Given this list of marker genes CCDC159, IPMK, TMEM184B, SOX15, ID3, FILIP1L, GSDMC, ZNF230, STX12, ZNF750, IRX4, PTGES, BTNL9, SAP130, ETV1, LZTS2, EDN1, HOXA5 (NCBI Gene Id 55953), TUBG1, TUT7, MEAK7, NFKBIL1, NR3C2, NR5A1, SPPL2B, ZNF252P-AS1, SLC4A9, DDX6, CLIC6, CYS1, SAMD11, GLDN, GALNT8, POLR1E, WNT10A, KRTAP2-4, NNMT, CACNA1I, KRCC1, TUSC2, TRABD2A, FLJ13224, NMNAT3, TRIM7, PYGL, ITPRIP, REXO1, NPL, FGGY, ACTR3B, DAD1, PBX4, FNBP1, CRMP1, BAZ2A, DNAL1, FXYD7, RAB13, NKX3-1, SPACA3, MPP4, BLVRA, GLCCI1 (NCBI Gene Id 113263), TMEM260, POLL, PPEF2, HTR6, ZNF563, WASF3, PSMB4, OPRK1 (NCBI Gene Id 4986), DHRS4-AS1, HSP90AA1, TTC39B, FCAR, CLIP4, DUSP18, AFG2A, TRPC1, FOLH1B, FAM53B, ANKRD35, MT1HL1, LILRA1, ANKRD36, RAB29, RAPSN, UNC5CL, NPC1L1, GALE, FILIP1, SLC16A3, SIK2, KRT222, TRNP1, RPS16P5, CETN1, SMCR5, PGBD1, EPS15, CLPTM1, NKX6-3, SMCHD1, NUDT16, ANKRD40, ZFPL1, TTC23L, BBS12, CDK8, USP48, CFAP47, FGF14-AS2, CFAP20, ZNF251, CD151, PANTR1, PLAUR, CHRNA9, NEK7, HNRNPA2B1, SLITRK2, USP44, BTBD9, ZNF674-AS1, ITGB5, LINC01619, LRRC14, DLG3, A1BG, CYP2F1, CYBA, VPS29, BNIP3, PPP1R3B, PLEKHO2, MOXD1, MAP3K2, ZNF416, HSPB1, IFITM2, ENSG00000254531, RBKS, PCF11, MEF2A, NASP, PPFIBP1, HOXB8, SULT4A1, SECTM1, KMT2E, SDR39U1, UBE2W, RAPGEF4-AS1 (RAPGEF4 antisense RNA 1), PCDHGA4, LYSMD1, ST6GALNAC6, THRAP3, ABHD12B, NAALADL1, CD40, LMAN2L, ZFR2, HPSE, SMARCA2, SNED1, PET100, SLC11A2, POLR1HASP, UBE2Q1, FCHO2, CFAP210, GSTCD, C2orf81, ANXA2R, NXF5, GABPB1-AS1, LINC01242 (long intergenic non-protein coding RNA 1242), TMEM102, CDH7, LINC00907, SESTD1, ACAD9, LINC01711, LGI4, CALML3, BAZ2B-AS1, TCF20, FTHL17, ACSM3, ARHGAP30, RADX, DPP6, LZTFL1, here is a description of the gene set: Genes up-regulated in CD11b+ cells from BALB/c mice bearing C26GM colon carcinoma: spleen versus tumor. from publication Marigo I, Bosio E, Solito S, Mesa C, Fernandez A, Dolcetti L, Ugel S, Sonda N, Bicciato S, Falisi E, Calabrese F, Basso G, Zanovello P, Cozzi E, Mandruzzato S, Bronte V (PMID 20605485) Tumor growth is associated with a profound alteration of myelopoiesis, leading to recruitment of immunosuppressive cells known as myeloid-derived suppressor cells (MDSCs). Analyzing the cytokines affecting myelo-monocytic differentiation produced by various experimental tumors, we found that GM-CSF, G-CSF, and IL-6 allowed a rapid generation of MDSCs from precursors present in mouse and human bone marrow (BM). BM-MDSCs induced by GM-CSF+IL-6 possessed the highest tolerogenic activity, as revealed by the ability to impair the priming of IFN- -producing CD8+ T cells upon in vivo adoptive transfer. Moreover, adoptive transfer of syngeneic, GM-CSF+IL-6-conditioned MDSCs to diabetic mice transplanted with allogeneic pancreatic islets resulted in long term acceptance of the allograft and correction of the diabetic status. Cytokines inducing MDSCs acted on a common molecular pathway. Immunoregulatory activity of both tumor-induced and BM-derived MDSCs was entirely dependent on C/EBP transcription factor, a key component of the emergency myelopoiesis triggered by stress and inflammation. Adoptive transfer of tumor antigen-specific CD8+ T lymphocytes resulted in therapy of established tumors only in mice lacking C/EBP in myeloid compartment. These data unveil another link between inflammation and cancer and identify a novel molecular target to control tumor-induced immune suppression. We used gene expression analysis to identify those factors, secreted by tumor-infiltrating MDSC, which could drive emathopoiesis. Moreover we compare gene expression profile of tumor-induced MDSC, obtained from either the spleen and the tumor infiltrate of tumor bearing mice, and in vitro bone marrow-derived MDSC. Human Gene Set: GSE21927_SPLENIC_VS_TUMOR_MONOCYTES_FROM_C26GM_TUMOROUS_MICE_BALBC_UP studied in species Homo sapiens